Given this list of marker genes PPP2R3A, IGSF3, CRHBP, CLIP2, RORB, DCP2, IMMT, BCL2L11, PLEKHB2, SOCS1, IQSEC3, CRYGA, TRIB2, TRPV6, FCGR3B, HYAL3, OPRD1, WDFY3, IL10, CDH1, ZNF253, FNBP1, PTPRZ1, TULP3, ZDHHC18, KCNJ9, GALE, RPA1, GRM8, CHST10, PTGDR, PCDHA12, KCTD12, CPZ, FGL2, TMEM106C, P2RY14, PCLO, COQ9, FAIM2, EFNA3, IL1RN, GRIA3, SND1-IT1 (NCBI Gene Id 92498), CHM, CD8B, HLA-DQB1, S100P, EN2, ECD, NAAA, ARHGEF12, FMOD, NUDT1, COMMD4, TENM4, SEPTIN7, ATF5, FCER2, CAPN1, NR1H4, ANK2, YWHAQ, CCNB2, EVI2B, ZNF804A, SLA, KCNS3, CPT1A, CEP112, C9, ACADL, ETFB, TMEM131L, WIPI1, FGF7, MAP3K14, HOXB7, BTN2A1, ZNF415, SELL, SPP1, TMCO1, ADAMDEC1, ANKRD7, PRDX6, RAB30, HOXC11, CLC, RAD51AP1, CD8A, RAB11A, PTPRE, SI, KDELR1, SYCP2, LMO1, CLDN7, DYNLT1, GPR37, UGT2B7, MYOM2 (NCBI Gene Id 9172), SAR1A, ENPP1, STAR, IKBKE, STC1, ANXA1, KRT14, AVPR1A, NFIL3, RPL4, TRAF6, BMP6, SLC6A1, MAL, SPN, PRKX, FGF4, PDHA2, GJA5, ECHS1, WWOX, KRTAP26-1 (keratin associated protein 26-1), CALCR, GUCY1A2 (NCBI Gene Id 2977), AMELY, RNASE2, ICAM4, STS, RASAL2, APOBEC2, ECM2 (extracellular matrix protein 2), HPD, H2AP, WNT5A, MAPK4, PTGER2, RRBP1, CCDC9, S100A11, EEF1AKMT3 (EEF1A lysine methyltransferase 3), KLHL18, LRRN3, EIF4G3 (eukaryotic translation initiation factor 4 gamma 3), C1QL1, RUNDC3A, ISL1, PTPN13, REEP5, IL18RAP, FLRT2, HSD17B8, NR0B2, PHYHIP, PNMA2, SPINT2, DDT, APOC1, TGFB1I1, TP53BP2, GFI1, HSF2BP, NUDCD3, IL18, TDRD7 (NCBI Gene Id 23424), ADH1C, TRIM52, BRINP2, ERCC8, CLDN10, GP1BB, REM1, CLCN2, MFAP4, FARP1, UGT2B4, SLC1A3, KLRK1, IL4R, SELP, SOCS3, RTL8C, EDIL3 (NCBI Gene Id 10085), UNC5B, CYTIP, CPA2, PAH, HOXB5, KCNJ13, PAPSS2, PMAIP1, RIPK2, DDX51, PRNP, WNK1, UCP2, S1PR1, TRHR, here is a description of the gene set: Inhibition of miR-33 results in increased cholesterol efflux and HDL-cholesterol levels in mice. In this study we examined the effect of miR-33 inhibition in a mouse model of atherosclerosis and observed significant reduction in atherosclerotic plaque size. At the end of the study, gene expression in macrophages from the atherosclerotic plaques was assessed. The results demonstrated a reduction in inflammatory gene expression and increased levels of mRNAs containing miR-33 binding sites. Human Gene Set: GSE28783_ANTI_MIR33_VS_CTRL_ATHEROSCLEROSIS_MACROPHAGE_UP studied in species Homo sapiens from publication Rayner KJ, Sheedy FJ, Esau CC, Hussain FN, Temel RE, Parathath S, van Gils JM, Rayner AJ, Chang AN, Suarez Y, Fernandez-Hernando C, Fisher EA, Moore KJ (PMID 21646721) Genes up-regulated in atherosclerosis macrophages: anti miR-33 versus anti miR.